Given this list of marker genes HBD, CD24, APOA4, CST7, ATP1B2, TULP1, MEGF9, SERPINA6, COL6A2, BAAT, EPOR, PTGER3, ATF5, APOB, VTN, PPBP, NRTN, FKBP8, CYP4A11, NTSR2, AGPAT2, APCS, FST, GREM1, MCM2, LAMB2, ALPL, C4BPA, FAM107A, AMT, RAC2, RIBC2 (NCBI Gene Id 26150), GJB1, CFB (NCBI Gene Id 629), TDO2, PIM1, TGM2, PSG7, FGL1, C1S, GCLM, PON3, NR0B2, HPD, CITED2, BCAM, COL2A1, METTL1, AQP3, CYB5A, ACAA1, STARD5, PTP4A1, IQGAP2, CPB2, TIMP3, MFAP2, FADS2, KCNQ1, APOC3, ANPEP, C6, CNN3, APOH, RBP1, PPP5C, PCK2, DSP, LMO2, LDOC1, PCLAF, NFIL3, GPC3, IL32, PPP1R1A, PNRC1, ITIH2, ACTN1, KLKB1, AGT, CCL7, CYP2A7, F10, RARRES2, FUT1, C2, NAT8, DLC1, SLC2A3, ETFB, ECHS1, ALDH1A1, TNXB, GSTT1, CEACAM3, RHOB, AGTR1, ITIH3, SERPINC1 (NCBI Gene Id 462), IGFBP3, GSTM1, COL1A1, HYAL1, TFR2, HSPG2, MEN1, ARHGEF16, FETUB, PYGL, ST3GAL4, CYP2A6, SORD, NHERF1 (NCBI Gene Id 9368), AMELX, EFNA2, SERPINA5, PHLDA2, CYP3A4, SERPINA4, DNASE1L3, TNFRSF1B, CYP27A1, GALR3, TGFBI, DNM2, PCBD1, GPX3, KRT86, ITGA5, SLC4A1, GATM, QDPR (quinoid dihydropteridine reductase), SLPI, SMPDL3B, GDF15, C8B, EPAS1, TRIB1, SBNO2, RNASE4, TRPM2, RBMS3, C5, HAP1, H4C3, TMCC2, NEURL1, AADAC, CDC42EP1, IGFBP4, APOC2, ADH1A, EPHX1, CD14, AANAT, DPP6, TFAP2B (NCBI Gene Id 7021), RNASE3, TMED3 (transmembrane p24 trafficking protein 3), SLCO2B1, HPR, SPP1, SRPX, SETD1B, RND1, AK4, SERPINA1, PRG2, NR1D1, KRT18, TBC1D2B, LGMN, CCN1, RGS10, SLC22A18AS, CLUH, LECT2, FCGRT, COL5A2, NECTIN2, PPP4R2, NNMT, CRYZ, ACO1, CHRNB1, PLA2G2A, FGFR4, JAK3, RNF167, ST6GAL1, APOE, SERPIND1, GMPR, DPT, CTSG, PCOLCE, CKS2, TMEM106C, AHSG, MSX1, PEG3, CCL15, ALDH4A1, PON2 (paraoxonase 2), FBN2, TM4SF5, TTLL12, GTSE1, HTR2A, FGFR3, SCO2, MSMO1, EGFR, ST6GALNAC4, PF4, H2BC12, LDLR, TBCD, ID2B, RGN, MST1, GCH1, FXYD1, ARG1, JUNB, SLC6A2, RHAG, HPN, CDH4, KCND3, STAB1, AGXT, LLGL2, MPP1, C4BPB, MAP2K3, NNAT, SPP2, FKBP1B, DEFA3, ITIH4, UBE2C, CDH1, COL6A3 (collagen type VI alpha 3 chain), SOD3, CARD10 (NCBI Gene Id 29775), LRP1, GLRX, P4HA1, MAOA, PPP6R2, CLEC3B, ACSL4, PPP1R15A, SMOX, HBZ, VSNL1, DDIT4, ACADSB, FGA, NXPH4, MMP11, AQP5, ALB, SRRM2, VSIG4, LAIR1, SLC6A8, AKR1C1, IGF2, ALAS2, IGFBP2, IL1R1, PTPRO, SYNPO2L, ABLIM3, PEG10, PNP, XK, ALDOB, SLC37A4, CYP2J2, CDK5R1, FUCA1, TM4SF4, PTTG1, GDPD5, IFIT1, HSPB2, FGB, FBP1, MTHFS, MT1G, PLG, SERPINF2, RHBDL1, AZGP1, CACNB1, APOC1, DKK4, HTR4, LTF, GCHFR (NCBI Gene Id 2644), AQP1, TM7SF2, ABCA1, ALAS1, CYB561, IHH, IGSF1, ZYX, ANXA9 (annexin A9), C1QB, IKBKG, KCNJ4, RIDA (NCBI Gene Id 137671), PRTN3, ELL2, UBE2L6 (ubiquitin conjugating enzyme E2 L6), CFAP410 (cilia and flagella associated protein 410), SPN, COL1A2, GOT1, COL6A1, IGFBP1, CCHCR1, DHRS3, IL4R, HMGCS2, ITIH1, SERPINE1, HMOX1, KNG1, GYPB, DRD2, MICAL2, MAOB, UBXN1, TCF7, ECM1, AMBP, COL4A1, CD163, MPO, CYP3A7, S100A9, FN1, SLC6A11 (NCBI Gene Id 6538), SHMT1, PIM2, MOK, APOA1, PCNA, GCLC, AAK1, CSF3R, GYPA, FOLR1, DLK1, ACKR1, COL3A1, VEGFA, ASGR2, GC, HGD, TNFRSF10B, SERPINA3, BHMT, LCAT, FABP1, CCND1, PAH, TNFRSF25, TYR, ENG (NCBI Gene Id 2022), ASGR1, SLC25A1 (solute carrier family 25 member 1), NUPR1, ADM, F2, DOK1, ETS2, PTPRD, SELENOP, ECI1, F12, GADD45G, CFI, S100A4, TRIM16, HP, S100A8, IL1RN, HSPA6, ACSL1, RBP4, CYP2B6, SRGN, PHYH, ARHGDIG, PLK3, CFHR1, PLIN2, SLC43A1, ITGA2B, ABCC6, PLEC, EFNA1, RNASE2, UGDH, IER3, GATA1, ELN, SDS, AKR1C3, CFH, HPGD, UGT2B15, ABAT, SCP2, COL9A1, SLC29A1, BCL2L1, CYP2E1, APOM (NCBI Gene Id 55937), PCK1, INHBC, WAS, SDC1, LBP, CLDN5, FXYD2, SERPINH1, INSIG1, HRG, RBM38, DDT, BLVRB, CPS1, DLEC1, DDC, CDC20, APOC4, ATOSB, FADS1, PROC, LAPTM5, ORM2, HAGH (hydroxyacylglutathione hydrolase), MTHFR, ITGB5, PDGFRA, HTR3A, here is a description of the gene set: studied in species Homo sapiens Human Gene Set: MODULE_24 Fetal liver genes - metabolism and xenobiotics.